Given this list of marker genes GNAQ, KISS1, GNA11, PRKCG, PLCB4, PLCB1, PLCB2, PLCB3, KISS1R, PRKCA, PRKCB, here is a description of the gene set: Human Gene Set: KEGG_MEDICUS_REFERENCE_KISS1_KISS1R_PLCB_PKC_SIGNALING_PATHWAY studied in species Homo sapiens Pathway Definition from KEGG: KISS1 -> KISS1R -> (GNAQ,GNA11) -> PLCB -> (Ca2+,DAG) -> PKC KISS1-KISS1R-PLCB-PKC signaling pathway. Pathway ID: N00869. Pathway type: Reference. Pathway class: nt06323 KISS1-GnRH-LH/FSH-E2 signaling.